Given this list of marker genes Abhd13, Abhd12 (NCBI Gene Id 99394), Abhd17c, Lypla1, Abhd17b, Abhd10, Abhd17a, Desi1, Lyplal1, Ppt1, Cpt1c, Lypla2, Desi2, Ppt2, here is a description of the gene set: Mouse Gene Set: GOMF_PALMITOYL_PROTEIN_HYDROLASE_ACTIVITY Catalysis of the reaction: palmitoyl-protein + H2O = palmitate + protein. studied in species Mus musculus